The following is a description of a gene set: Neighborhood of NPM1 nucleophosmin (nucleolar phosphoprotein B23, numatrin) in the GNF2 expression compendium Neighborhood of NPM1 studied in species Homo sapiens Human Gene Set: GNF2_NPM1, and this is the list of marker genes: NAP1L1, GNL3, RPL5, RPS24, SNRPD2, NOL7, RPL26, DNAJC2, SRSF1 (NCBI Gene Id 650453), SNRPD1, HNRNPA1, HMGN1 (NCBI Gene Id 3150), TCERG1, RPL7, LRPPRC, NOLC1 (nucleolar and coiled-body phosphoprotein 1), POLR3E, EIF3L, BTF3, EIF3A, FASTKD1, RPS3, RPSA, RPS25, SLC7A5P1, RPL6, CPSF6, EIF3E, HNRNPR, HSPA4, RPS7, LSM7, SERBP1, CLNS1A, NAE1, SNRPD3, NUP43, SSBP1, NOL11, RRP1B, RPL17, NCL, DKC1, RPL7A, RPL14, TARDBP, FBL, HNRNPC, KARS1, PUM3, AIMP1, RTRAF, RPL4 (ribosomal protein L4), CCT8, RPL37, EIF3M, XPO1, DDX39B, PPIA, SNRPE, GTF3C3, HNRNPA2B1, RPS6, DHX15 (NCBI Gene Id 1665), ST13, SSB, GTPBP4, RPS17, DIMT1, NPM1, LSM5, RBMX